Given this list of marker genes HDAC2, NCOA1, WBP2, NEDD4, ERRFI1, UBE3A, PGR, PHB1, TRERF1, UBR5, ZDHHC7, SRC, here is a description of the gene set: A nuclear receptor-mediated signaling pathway initiated by a progesterone binding to an intracellular receptor of the nuclear receptor protein family, and ending with regulation of a downstream cellular process, e.g. transcription. species: Homo sapiens Human Gene Set: GOBP_PROGESTERONE_RECEPTOR_SIGNALING_PATHWAY